Given this list of marker genes Arid4b, Ttc38, Slc4a8, Cntn4, Ghsr, Hip1, Kmt2c, Plekhh2, Pth, Sncg, Tmem209, Ergic1, Tent4b, H3f3a, Fam217a, Slc19a3, Lce1l, Reps2, Adgrg7, Rspry1, Ctnna2, Tph2, Tmem135, Dll1, Wtap, Gpx8, Olfm1, Ets1, Ppil4, Ajuba, Casp7, Usp37, Rapgef2, Klf6, Zbtb6, Wdr59, Pcgf6, Impg2, Tet3, Nars1, Ldlrad4, Smad1, Wapl, Chmp5, Bpnt1, Lamc1, Nfat5, Set, Otud4, Strn3, Klf4, Pip4p2, Pdha1, Mylk, Gm12886, here is a description of the gene set: Mouse Gene Set: MIR_12203_3P species: Mus musculus from publication Chen Y, Wang X (PMID 31504780) Genes predicted to be targets of miRBase v22 microRNA mmu_miR_12203_3p in miRDB v6.0 with MirTarget v4 prediction scores > 80 (high confidence targets).